Given this list of marker genes LIN7A (lin-7 homolog A, crumbs cell polarity complex component), GOLM2, PPP3R1, TAF1A, NR2E1, SEPSECS, CPS1, PAX3, SNX4, LRRC1, PECAM1, STMN2, HTR6, PAIP2, R3HDM1, GPRASP1, ZNF195 (NCBI Gene Id 7748), WNK1, ZNF284, PPP2R2D, ZNF131, LDLRAD4, ZNF587, ATXN1, CRYAB, AKAP11, NADK2, PLXNC1, DPF3, DBT, LOX, IRGQ, CPE, NFATC3, ID2, OTC, CCDC62, PLEKHG6, TAFA1, PACS2, FBXO45, PYGO1, HIPK1, DKK2 (NCBI Gene Id 27123), LCLAT1, MYCN, DENND6A, HIVEP2, SCN3B, COG3, SPRY3, EID2, PABIR2, SRD5A2, ALDH6A1, DGKD, PHACTR1, USP13, UBE2H, ORAI2, NR4A3, MGAT2, ASIC4, TMEM33, PLEKHH1, LRRC47, KPNA1, NTRK2, SAV1, FBXO3, ARRDC3, FOXJ3, JARID2, TENT4B, SLC4A4, CCNY, CRISPLD2, NLGN1, ZNF98, KIF5C, CPEB3, CPNE8, ZDHHC14, GPHN, SLC30A4, ARL14EP, BCL7A, STXBP1 (NCBI Gene Id 6812), CCND2, SS18L1, STK4 (NCBI Gene Id 6789), SIAH1, SNX12, PLEKHA5, NPL, XKR6, FAM117B, DMRT3, UBE2R2, NELL1 (NCBI Gene Id 4745), VHL (NCBI Gene Id 8056), NEGR1, ZBTB34, CCNT2, SOS2, ZNF101, GIT2 (GIT ArfGAP 2), PKIB, CCNE1, NDUFA10, PRND, DIO2, LCE1E, TARDBP, GUF1, MTUS2, ARHGAP35, CHEK1, SRSF2, ARHGDIA, ADAMTS6, SMAD9, EPB41L4B, TWSG1, ZNF148, ADRA2A, COL7A1, RYBP, ADI1, HUS1, here is a description of the gene set: from publication Chen Y, Wang X (PMID 31504780) Genes predicted to be targets of miRBase v22 microRNA hsa-miR-383-3p in miRDB v6.0 with MirTarget v4 prediction scores > 80 (high confidence targets). studied in species Homo sapiens Human Gene Set: MIR383_3P